Given this list of marker genes HSD11B1, HEATR3, FHAD1, IRGM, DENND2B, MTFR1L, GRWD1, EEIG1, NT5C2, RRP12, PORCN, FZD2, OSGIN1, LEPROTL1, ERI3, PACS2, TRIO, FLT3LG, ENC1, CANT1, CRTAC1, POLR1B (RNA polymerase I subunit B), TGM2, GLRX, PNPLA7, CZIB, SERPINA12, NFU1, DACH1, PCDHB3, MBP, B4GALT1, IMP3, BYSL, PADI2, SLC12A5, SLC37A1, TSPO, DHODH, PIM2, MGAT4A, STAT1, DPP4, SEMA4A, NOB1, TBC1D5, DDX59, FCRL1, CTH, FHIP1B, LAT, KAZALD1, IKBKB, IGFBP4, DRC1, POLR3B, DZIP1, PDE11A (phosphodiesterase 11A), ACP3, TRIM26, HSPBP1, GOLIM4, BORCS8, DIP2C, EMG1, DIDO1, MYO3B (NCBI Gene Id 140469), DSE, ATRAID, GBP2, MMUT, CIB3, PWP2, EYA2, TAPBP, GPM6B (NCBI Gene Id 2824), ACCSL, PDLIM1, FXYD2, SCG5 (secretogranin V), PRKCQ, CD86, EFS, TAPT1 (NCBI Gene Id 202018), VAMP2, ALS2CL, DPP8, ANKRD39, DHX33, TRUB1, SNAI1, MITF, VTA1, GNAO1, MDFIC, SYNJ2, ACVR1B, C1QTNF1, DPH6, NFIX, PTPN9, CA14 (NCBI Gene Id 23632), CACNA1C, TRIOBP, MORC2, MYO6, ACAT1, ITPR3, MLH1, RCAN3, TTC27, NLRC5, PIK3R5, C19orf48P, SMG8, BCL7A, PDK1, PDLIM4, FLJ13224, SLC39A11, SECISBP2, COIL, FOCAD, GALNT6, NCF4, MANEAL, FASTKD1, PCBD1, RRP15, TPST2, SLC4A1AP, IL2, PDCD11, DPH5, SMPD1, EFR3A, TNFSF13B, ADH1C, SHD, TPRN (NCBI Gene Id 286262), BCL9 (NCBI Gene Id 607), ZBTB25, ARL4C, TMEM121, GPATCH4, TMEM41A, RHOBTB2, CCDC86, AEBP1, MMP9, WFDC1, SLC5A6, PHLPP2, WDFY1, BRAP, TMEM175, CLUH, MCOLN2, TFIP11, MBOAT1, DNAJC11, ARSB, LONP1, SQLE (NCBI Gene Id 6713), BAG6, DENND1C, GLMN, USP36, NPC2, HSF1, ZFP90, MRPS23 (NCBI Gene Id 64952), LRRTM3 (leucine rich repeat transmembrane neuronal 3), NABP1, PSMB10, DCAF1, TMEM222, GMEB2, SMYD1, BTBD19, HESX1, ALG5 (NCBI Gene Id 29880), ECE2, ADCY3, TOR1AIP1, EFHD2, MDN1, OGFOD1, TMEM192, CFAP141, BTC, DAPL1, SLC16A5, GBP7, EFTUD2, TK2, ADGRE5, SFN, DENND2D, here is a description of the gene set: species: Homo sapiens Genes up-regulated in comparison of regulatory T cell (Treg) from IL2RB defficient mice versus regulatory T cell (Treg) from wild type animals. from publication Yu A, Zhu L, Altman NH, Malek TR (PMID 19185518) Human Gene Set: GSE14350_IL2RB_KO_VS_WT_TREG_UP Interleukin-2 receptor (IL-2R) signaling is essential for T regulatory (Treg) cell development and homeostasis. Here we show that expression of IL-2Rbeta chains that lack tyrosine residues important for the association of the adaptor Shc and the transcription factor STAT5 in IL-2Rbeta-deficient mice resulted in production of a normal proportion of natural Treg cells that suppressed severe autoimmunity related with deficiency in IL-2 or IL-2R. These mutant IL-2Rbeta chains supported suboptimal and transient STAT5 activation that upregulate the transcription factor Foxp3 to normal amounts in natural, but not induced, Treg cells. Using cells T cell obtained from normal C57BL/6 mice and mice harboring Treg cells with impaired IL-2R signaling, gene expression profiling revealed many targets in peripheral natural Treg cells that were IL-2-dependent and a substantial overlap between the Treg cell IL-2-dependent gene program and the Treg cell transcriptional signature. Collectively, these findings demonstrate that a critical, and perhaps minor, subset of IL-2-dependent targets in Treg cells is indexed to a low IL-2R signaling threshold and that a substantial proportion of the Treg cell gene program is regulated by IL-2. CD4 T effector cells also showed many IL-2R-dependent gene and these also overlapped in a distintive manner with the IL-2-dependent genes of Treg cells and the Treg gene signature.